The following is a description of a gene set: species: Mus musculus Mouse Gene Set: WP_APOPTOSIS_MODULATION_BY_HSP70 Apoptosis modulation by HSP70, and this is the list of marker genes: Casp7, Casp9, Casp6, Casp2, Mapk10, Hspa1a, Casp3, Fas, Bid, Nfkb1, Aifm1, Tnfrsf1a, Ripk1, Apaf1, Casp8, Map3k1